The following is a description of a gene set: from publication Chen Y, Wang X (PMID 31504780) Genes predicted to be targets of miRBase v22 microRNA hsa-miR-608 in miRDB v6.0 with MirTarget v4 prediction scores > 80 (high confidence targets). studied in species Homo sapiens Human Gene Set: MIR608, and this is the list of marker genes: OLFM2, NAV2, C1QB, FBXO46, ITPKB, PCDHGA3, BSN, RCVRN, VAT1, FOXP4, CHST14, IGLON5, RC3H1, LDB3, TBX6 (T-box transcription factor 6), PCDHGA2, LSMEM2, ZBTB7A, KIF21B, TTBK1, CHRM1, DPF2, EGFR, WDTC1 (NCBI Gene Id 23038), RIMBP2, FGD4, VDR, NPTXR, YY1AP1, NME4, DNAJC8, PIGL, SYNGAP1, SGSM2, NR4A1, JADE2, PODXL, COX15, FNDC10, MAP3K13, NALF2 (NCBI Gene Id 27112), PFKFB3, GP6, CSRP1, EFNA5, ABCC12, GPX3, RFX1, KCNK9 (NCBI Gene Id 51305), KPRP, MAB21L2, CALB2, GFAP, SZRD1, ATP1B2, PIERCE1, TFAP4, RHOF, LMOD1, IQSEC2, EPHA8, SLC48A1, ENTPD2, SLC1A7, GRAMD4, SOD3, SSBP3, DVL3 (NCBI Gene Id 1857), AK2, FAM107A, KCNC4 (NCBI Gene Id 3749), SCRT1, TBC1D16, PCDHGC3, SPTBN4, ERF, RHBDL3, PCDHGA10, TOM1L2, PCDHGB3 (protocadherin gamma subfamily B, 3), TMEM61, TTYH3, MMP24, KLF16, SLC7A8, SNX20, NEUROD6 (NCBI Gene Id 63974), ACTR1A, AAK1, CPLX2, HMGXB3, ELAVL3, PCDHGA11, DLX3, FOXO4, TMCC3, PLXNA4, CYP2W1, SFTPA2, SOX12, FAM219A (family with sequence similarity 219 member A), C19orf53, PAX5, SPRY4, SH3BP4, NKD1, DDA1 (DET1 and DDB1 associated 1), PPP1R9B, KCNH1, ZDHHC3, RGS6, PCDHGA12, EPN1, GRIN2A, PATZ1, CCL21, FAM177B, NACC1, RAI1, MDGA1, ARRB1, LHPP, DNAJB5, POU4F1, PCDHGA9, A1CF, FOXI1, NOVA2, RAB25, SEPTIN9, PARVB, DAGLA, MSI1, CASTOR2, PCDHGA7, TWIST2 (NCBI Gene Id 117581), BCAM, EEF1A1, LRRC32, ZMYND11 (NCBI Gene Id 10771), SNX19, WFDC5, NHERF1, TRIM33, GNG4 (NCBI Gene Id 2786), SARDH, SLC45A3, ASIC1, CARM1, LHX6, RTN4R, PRPS1, VSTM2L, WFIKKN2, NFIC, CUX1, RCC2, CRHR1, IGFBP5, ANKRD52, MUC3A, FZD8, NFIX (nuclear factor I X), SLC8A2, WIPF2, RASL10B, MEX3A, PRIMA1, DDN (NCBI Gene Id 23109), PCDHGA8, MAP1A, MEOX1, ZNF609, SGCD, RSPRY1, CELSR2, ZC3H7B, CDKN1A, MKNK2, GORASP1, PTPN14, HYOU1, NECTIN1, CDSN, ZNF584, ONECUT2, SCN2B, SEMA4G, NTSR1, FCRLA, SRCIN1, PCDHGA1, SIX3, AIPL1, LIMD2, FZD4, PCDHGB7, CFAP251, HIVEP3, RAVER1, PITPNM2, PCDHGA5, PIWIL3, ATF7, GIT1, PRAF2, IQSEC3, KSR2, DMWD, ZBTB7B